The following is a description of a gene set: studied in species Mus musculus Mouse Gene Set: GOBP_REGULATION_OF_DOPAMINE_SECRETION Any process that modulates the frequency, rate or extent of the regulated release of dopamine., and this is the list of marker genes: Rtn4, Chrna6, Npy2r, Htr6, Drd2, Dtnbp1, Htr1b, Pink1, Drd3, Syt11, Abat, Htr2a, Snca, Syt4, Prkcb, Pcp4, Rab3a, Cxcl12, Chrna4, Kcna2, Syt1, Oprk1, Chrnb2, Gabbr1, Sncg, Grm2, Cnr1, Syt7, Slc18a1, Myo5a, Entpd1 (NCBI Gene Id 72476)